Given this list of marker genes A1BG, TP53, LAMTOR4, PRSS27, TSSC4, ZBED6, ELF1, CIB4, CIRBP, WDR46, USP20, PTOV1, INTS11, UQCRC1, H1-3 (H1.3 linker histone, cluster member), BBOF1, CD37, LRP3, FOXM1, MRTFA, RFTN1, PWP1 (PWP1 homolog, endonuclein), C6orf136, GYG2, PHF5A, GTSE1, LTBP4, SRPK2, JUND, CHD4, CAMKMT, ANK1, ALOX12P2, RARRES2, MBP, HRH3, ZNF609, EPM2AIP1, TM4SF1, PCIF1, CCDC71L, GTF3A, LTBP3, DAXX, MTA2, UBN1, SNX24, SV2A (NCBI Gene Id 9900), KCNJ11 (potassium inwardly rectifying channel subfamily J member 11), ASIC3, PAM16, PAQR7, TMSB10, CAPZB, MAN1B1-DT, FAM153A, C19orf48P, METTL14, PLCH2, GCDH, TBC1D10C, GALNT17, DDX27, CEP85L, RAB40B, NRBP1, FOSB, RAB12, SCAF4, CHCHD10, TAF1D, PMF1, FAM3A, RICTOR, OR2C3, SLC66A2, PTP4A2, H2AX, RAB7A, SHKBP1, PPEF1, SIGIRR, CEP70, AP1S1, PPP5C, MMP14, MYCT1, RNF128, PNISR, DTX2, LRSAM1 (leucine rich repeat and sterile alpha motif containing 1), UBA1, NFATC4, LINC02893, USP10, LINC00900, TARDBP, H2AJ, BBLN, ZMYND8, EMP3, PRRC2A, MKNK2, SIRPD, GARS1, SLC25A37, ATP1B1, BMP5, THRA, AASDH, G6PD, UTP23, PREX1, MARVELD2, SRRM5, GDAP1, LRP5 (LDL receptor related protein 5), CCDC125, CCDC78, NICOL1, DDX23, VPS18, ENDOV, UBALD1, AKT1, PRDM6, PPP1R15A, UQCC3, ST3GAL2, NOP14, SZRD1, WNT5B, GPR45, ILRUN, PDXDC2P, ILF3-DT, SOST, HDAC9, NAF1, POLR1G, ADRM1, PPM1G, LTB, FYB1, EIF3G (eukaryotic translation initiation factor 3 subunit G), TGFB1, LINC01579, B4GALT5, PPP1R14A, RBM42 (NCBI Gene Id 79171), TRIM41, FBXL15, CLBA1, C1orf167, RPRD2, SPATA20, TNIP1, RNF122, ACTN4, ESAM, MOSMO, MBD6, ACTR1A, NCOA2, NKRF, GNA15, DMTN, FAM106A, NAA80, GABRA6, UNC13D, PHF12, ANXA11, BCL7A, GMDS, NCKIPSD, CBX5, NCOR2, OR5AK4P, ANKRD36, MTG2, QPRT, KDM5A, STING1, RFNG, CROCC, LINC01553, GPRC5C, UTP4, HSPG2, FAAP20, MFN2, here is a description of the gene set: species: Homo sapiens Human Gene Set: GSE6259_BCELL_VS_CD4_TCELL_UP Genes up-regulated in B lymphocytes versus CD4 T cells. Dendritic cells (DCs) process and present self and foreign antigens to induce tolerance or immunity. In vitro models suggest that induction of immunity is controlled by regulating the presentation of antigen, but little is known about how DCs control antigen presentation in vivo. To examine antigen processing and presentation in vivo we specifically targeted antigens to the two major subsets of DCs using chimeric monoclonal antibodies. Unlike CD8+ DCs that express the cell surface protein CD205, CD8- DCs, which are positive for the 33D1 antigen, are specialized for presentation on MHC class II. This difference in antigen processing is intrinsic to the DC subsets and associated with increased expression of proteins associated with MHC processing. from publication Dudziak D, Kamphorst AO, Heidkamp GF, Buchholz VR, Trumpfheller C, Yamazaki S, Cheong C, Liu K, Lee HW, Park CG, Steinman RM, Nussenzweig MC (PMID 17204652)